Given this list of marker genes Cnga4, Rab11a, Exoc7, Gbf1, Rho, Arf4 (ADP-ribosylation factor 4), Rab3ip, Cngb1, Pkd2, Cnga2, Pkd1, Exoc3, Exoc5, Asap1, Rab11fip3, Exoc2, Rab8a, Exoc8, Exoc1, Exoc4, here is a description of the gene set: VxPx cargo-targeting to cilium species: Mus musculus Mouse Gene Set: REACTOME_VXPX_CARGO_TARGETING_TO_CILIUM